Given this list of marker genes PSMD14, BTRC, UBA3, SEM1, PSMB7, PSMA5, PSMB4, UBB, PSMD6, MAP3K14, PSMD12 (proteasome 26S subunit, non-ATPase 12), PSMA2, SKP1, UBA52, PSMC2, PSMB5, PSMA3, NFKB2, PSMC4, CHUK, PSMA6, PSMB1, PSMC6, PSMC1, PSMB2, CUL1, PSMD3, PSMD13, PSMD8, PSMA1, PSMA4, RPS27A, PSMD11, FBXW11, UBC, ADRM1, RELB, PSMC5, UBE2M, PSMC3, PSMD2, PSMA7, PSMB3, PSMB6, PSMD7, PSMD1, here is a description of the gene set: In addition to the activation of canonical NF-kB subunits, activation of SYK pathway by Dectin-1 leads to the induction of the non-canonical NF-kB pathway, which mediates the nuclear translocation of RELB-p52 dimers through the successive activation of NF-kB-inducing kinase (NIK) and IkB kinase-alpha (IKKa) (Geijtenbeek & Gringhuis 2009, Gringhuis et al. 2009). Noncanonical activity tends to build more slowly and remain sustained several hours longer than does the activation of canonical NF-kB. The noncanonical NF-kB pathway is characterized by the post-translational processing of NFKB2 (Nuclear factor NF-kappa-B) p100 subunit to the mature p52 subunit. This subsequently leads to nuclear translocation of p52:RELB (Transcription factor RelB) complexes to induce cytokine expression of some genes (C-C motif chemokine 17 (CCL17) and CCL22) and transcriptional repression of others (IL12B). part of: TNFR2 non-canonical NF-kB pathway studied in species Homo sapiens Reactome Pathway: NIK-->noncanonical NF-kB signaling